The following is a description of a gene set: studied in species Homo sapiens A detrimental reaction to a food, beverage, food additive, or compound found in foods that produces symptoms in one or more body organs and systems that is not mediated by an immune reaction. Food intolerance Human Gene Set: HP_FOOD_INTOLERANCE, and this is the list of marker genes: MLXIPL, ASXL1, COG8, ELN, ALG3, CLMP, GALT, SRCAP, UNC45A